Given this list of marker genes MTHFR, SERPINC1, HABP2, PGM1, F2, PROC, F13A1, PROS1, here is a description of the gene set: Formation of a blood clot (thrombus) inside a cerebral vein, causing the obstruction of blood flow. studied in species Homo sapiens Human Gene Set: HP_CEREBRAL_VENOUS_THROMBOSIS Cerebral venous thrombosis